Given this list of marker genes SOX2, MYH3, MMP23B, GLI3, ODC1, LUZP1, PTCH1, PTCH2, NSD2, COG1, NELFA, PRKCZ, SPEN, HSPG2, ANKRD11, NXN, LFNG, ACTB, CTBP1, CHRNG, HES7, FOXF1, RECQL4, ROR2, MAP3K7, GABRD, CPLX1, FGFRL1, TBX6, SUFU, PIGG (phosphatidylinositol glycan anchor biosynthesis class G (EMM blood group)), UBE4B, SON, LETM1 (NCBI Gene Id 3954), SIX6, MESP2, PRDM16, SH2B1, TMCO1, SKI, KCNAB2, DLL3, CASZ1, RIPPLY2, RERE, PDPN, BRD4, here is a description of the gene set: Human Gene Set: HP_RIB_FUSION Complete or partial merging of adjacent ribs. Rib fusion species: Homo sapiens